The following is a description of a gene set: part of: Transcriptional regulation by RUNX1 species: Mus musculus This event has been computationally inferred from an event that has been demonstrated in another species.<p>The inference is based on the homology mapping from PANTHER. Briefly, reactions for which all involved PhysicalEntities (in input, output and catalyst) have a mapped orthologue/paralogue (for complexes at least 75% of components must have a mapping) are inferred to the other species. Reactome Pathway: RUNX1 regulates estrogen receptor mediated transcription electronically inferred by orthology from the curated human pathway, and this is the list of marker genes: Esr1, Cbfb (NCBI Gene Id 12400)